The following is a description of a gene set: A protein complex that acts as a chaperone or scaffold for centriolar proteins during the maturation of the procentriole. Some of its members may become integrated into the growing centriole. Examples are the CPAP(CENPJ)-STIL complex, CEP192-PLK4 complex or CEP152-PLK4 complex in vertebrates. Mouse Gene Set: GOCC_PROCENTRIOLE_REPLICATION_COMPLEX studied in species Mus musculus, and this is the list of marker genes: Sass6, Cep152, Stil, Plk4, Cep192, Cenpj